Given this list of marker genes Tbx2, Hoxa5, Fgfr2, Rspo2, Spry2, Hmga2, Hhip, Wnt2, Rdh10, Tmem67, Sox2, Ctsd, Celsr1, Sox9, Wnt2b, Nkx2-1, Foxa2 (NCBI Gene Id 15376), Esrp1, Tnf, Tnc, Fgf10, Ctsl, Foxa1, Dlg5, Dag1, Vangl2, Shh, Ctnnb1, Esrp2 (NCBI Gene Id 77411), Kras, Yap1, Ext1, Hhex, Tmtc3, Ctsh, Bmp4, Foxf1, Spry1, Lama1, Pdgfra, Ctsz, here is a description of the gene set: The process in which a highly ordered sequence of patterning events generates the branched epithelial tubes of the lung, consisting of reiterated combinations of bud outgrowth, elongation, and dichotomous subdivision of terminal units. Mouse Gene Set: GOBP_EPITHELIAL_TUBE_BRANCHING_INVOLVED_IN_LUNG_MORPHOGENESIS species: Mus musculus